Given this list of marker genes ACKR3, RBP1, MAF, ARL4D, BRINP2, GAD2, LHX6, PDZRN4, GAD1, NXPH1, SST, PAM, ARX, CXCR4, here is a description of the gene set: Human Gene Set: ZHONG_PFC_C7_SST_LHX6_POS_PUTATIVE_MIGRATING_INTERNEURON studied in species Homo sapiens from publication Zhong S, Zhang S, Fan X, Wu Q, Yan L, Dong J, Zhang H, Li L, Sun L, Pan N, Xu X, Tang F, Zhang J, Qiao J, Wang X (PMID 29539641)